The following is a description of a gene set: This event has been computationally inferred from an event that has been demonstrated in another species.<p>The inference is based on the homology mapping from PANTHER. Briefly, reactions for which all involved PhysicalEntities (in input, output and catalyst) have a mapped orthologue/paralogue (for complexes at least 75% of components must have a mapping) are inferred to the other species. part of: Metabolism of proteins electronically inferred by orthology from the curated human pathway species: Mus musculus Reactome Pathway: Surfactant metabolism, and this is the list of marker genes: Sftpd, Lmcd1, Ctsh, Adra2c, Ckap4, P2ry2, Gata6, Sftpb, Napsa, Adra2a, Adora2a